The following is a description of a gene set: studied in species Homo sapiens Human Gene Set: HP_SILVER_GRAY_HAIR Silver-gray hair Hypopigmented hair that appears silver-gray., and this is the list of marker genes: BLOC1S3, DSTYK, LYST, MYO5A, RAB27A, MLPH